Given this list of marker genes Hps6, Rapgef6, Ap1g1, Unc13b, Rac1, Rapgef5, Gchfr, Rab3a, Rab38, Dnm1l, Rab3c, Eea1, Rab5b, Rab32, Cdc42, Pard6a, Mras, Rab3b, Rab34, Dynlt1b, Arfip2, Ap3b1, Gch1, Rab3d, here is a description of the gene set: species: Mus musculus Binding to a protein or protein complex when at least one of the interacting partners is in the GTP-bound state. Mouse Gene Set: GOMF_GTP_DEPENDENT_PROTEIN_BINDING